The following is a description of a gene set: mouse primary BMDCs were stimulated with tlr ligands and gene expression changes were profiled on Affymetrix arrays from publication Amit I, Garber M, Chevrier N, Leite AP, Donner Y, Eisenhaure T, Guttman M, Grenier JK, Li W, Zuk O, Schubert LA, Birditt B, Shay T, Goren A, Zhang X, Smith Z, Deering R, McDonald RC, Cabili M, Bernstein BE, Rinn JL, Meissner A, Root DE, Hacohen N, Regev A (PMID 19729616) species: Homo sapiens Human Gene Set: GSE17721_PAM3CSK4_VS_GADIQUIMOD_0.5H_BMDC_DN Genes down-regulated in comparison of dendritic cells (DC) stimulated with Pam3Csk4 (TLR1/2 agonist) at 0.5 h versus DC cells stimulated with Gardiquimod (TLR7 agonist) at 0.5 h., and this is the list of marker genes: DHFR, IRF6, MYOZ1, CFH, UXT, RUFY1, NOS1, DAO, TBC1D17, NELFA, GBP4, HRH2, MCM3AP, ANAPC11, PLCL2, CEP57L1, BTK, YPEL5 (yippee like 5), PRIM2, FGF20, BICDL1, NR2F1, UBE2O, DEK, SLFN12, COL3A1, TMED4, TTF1, PIGK, PSMB10, CDC5L, C19orf25, SLC30A6, FOXE3, PSIP1, PEX6, LRRC26, WDR13, ANKH, COX7A2L, MAK16, VN1R5, WWC2, FGL2, LAMB2, HPD, ZNF362, SLC37A4, TNRC18, ZRSR2, ELMO2, NUCB2, TRIM15, UBE2D1, NAP1L4, FKBP8, USP9X, MOB3B, MRTFB, MGP, MTX1, IL1R2, SEPTIN4, ST3GAL4, TOMM7 (translocase of outer mitochondrial membrane 7), GABARAPL1, POLR3F (NCBI Gene Id 115527), ERLIN1, TPSG1, MINK1, ALG2, MAPK1, CCDC6, ACTR1A, MDFI, CDC34, SERTAD3, MS4A6A, LANCL2, TMEM260, PPM1A, PTOV1, SYNE1, HEPH, EPSTI1, ECPAS, FOXG1, SLC26A3, PPIL2, UBE2S, YEATS4, KLRK1, HTR7, AVP, FZR1, GP2, SYNE2, SH3BP5L, MKRN1, LARP1, NONO, RFK, TMEM234, CPPED1, NHERF1, AMIGO1, NRBP1, TMEM222, CABP7, ARL2, PLAC8, FXR1, DNER, GATAD1, NFATC2IP, PIP5KL1, POLR2A, CCDC85A, LIMD1, TMEM134, SMPDL3A, PPP3R1, PDZK1IP1, ITGA4, FABP6, CYFIP2, EPHX2, GPR180, PCOLCE, LY9, BTG4, TMCO6, INPP5B, LIPE, ATG12, RAB22A, TK1, FAM13B, LSM3, EDC4, SLC27A2 (NCBI Gene Id 8523), YWHAE, ABHD3 (NCBI Gene Id 90492), NHERF4, DUSP22 (dual specificity phosphatase 22), BOP1, LAMTOR5, TRIM8, ARG2, MMP20, GRIA4, NDUFB11, STX8 (syntaxin 8), TSC22D3, PRMT1, KDM5A, DHX16, VAV2, ATP5F1E, DDX46, IPP, BCKDHB, PIGT, DUSP18, FBXW11, SLC35A3, SPINK4, EDEM1, CELA1, PLAAT3, LSM12, RHBDL1, GOLGA2, SRPK2, SIGIRR, TNFRSF13B, UBE2V1, SGPL1, ARPC4, TRIM24, MED4, CKS1B, ADI1, TIPRL, LMAN1L, DRG1, FEZ1, FOXJ1, MED8, ZNF148, NUDT13, DCAF1, NUDT16, RRP15, ZMAT2, CHST12, OVOL2, P2RY12, DAXX, RNF44